Given this list of marker genes Ptpn18, Mapk14, Cox7a2l, Cd48 (NCBI Gene Id 98728), Cbr3, Dusp1, Tm6sf1, Ctsh, Ifngr1, Ckb, Otulinl, Cd81, Gpr68, Fos, Glrx3, Lyz2, Tgfbi, Klf4, Btg2, Niban1, Alox5ap, Adrb2, Pold4, Ucp2, Rack1, Unc119, Rab7b, H2az1, Arhgap18, Klf2, Trf, Adcy7, P3h2 (prolyl 3-hydroxylase 2), Cd300c2, Nap1l1, Tbc1d4, Hepacam2, Gdi2, Creg1, Cytip, Irag2, Npm1, Zfp36l2, Rtl8a, Gpx1, Erp29, Rgs10, Pmaip1, Irf2bp2, Gpi1, Ccr2, Kctd12, Rgs2 (NCBI Gene Id 19735), Aph1c, here is a description of the gene set: from publication Cui A, Huang T, Li S, Ma A, Pérez JL, Sander C, Keskin DB, Wu CJ, Fraenkel E, Hacohen N (PMID 38057668) Genes negatively differentially expressed in cell type: cDC1 (conventional dendritic cell type 1) upon treatment with cytokine: IFN-γ in mouse lymph nodes in vivo. species: Mus musculus Cytokines mediate cell-cell communication in the immune system and represent important therapeutic targets. A myriad of studies have highlighted their central role in immune function, yet we lack a global view of the cellular responses of each immune cell type to each cytokine. To address this gap, the authors created the Immune Dictionary, a compendium of single-cell transcriptomic profiles of more than 17 immune cell types in response to each of 86 cytokines (>1,400 cytokine-cell type combinations) in mouse lymph nodes in vivo. A cytokine-centric view of the dictionary revealed that most cytokines induce highly cell-type-specific responses. For example, the inflammatory cytokine interleukin-1β induces distinct gene programmes in almost every cell type. A cell-type-centric view of the dictionary identified more than 66 cytokine-driven cellular polarization states across immune cell types, including previously uncharacterized states such as an interleukin-18-induced polyfunctional natural killer cell state. Mouse Gene Set: CUI_CDC1_IFNG_RESPONSE_DN